The following is a description of a gene set: Mouse Gene Set: MCCLUNG_COCAIN_REWARD_4WK Genes up-regulated in the nucleus accumbens (a major reward center in the brain) after 4 weeks of cocaine treatment. from publication McClung CA, Nestler EJ (PMID 14566342) DeltaFosB (a truncated form of FosB) and CREB (cAMP response element binding protein) are transcription factors induced in the brain's reward pathways after chronic exposure to drugs of abuse. However, their mechanisms of action and the genes they regulate remain unclear. Using microarray analysis in the nucleus accumbens of inducible transgenic mice, we found that CREB and a dominant-negative CREB have opposite effects on gene expression, as do prolonged expression of DeltaFosB and the activator protein-1 (AP-1) antagonist DeltacJun. However, unlike CREB, short-term and prolonged DeltaFosB induction had opposing effects on gene expression. Gene expression induced by short-term DeltaFosB and by CREB was strikingly similar, and both reduced the rewarding effects of cocaine, whereas prolonged DeltaFosB expression increased drug reward. Gene expression after a short cocaine treatment was more dependent on CREB, whereas gene expression after a longer cocaine treatment became increasingly DeltaFosB dependent. These findings help define the molecular functions of CREB and DeltaFosB and identify clusters of genes that contribute to cocaine addiction. studied in species Mus musculus, and this is the list of marker genes: Traf6, Dnajc5, Per1, Gpaa1, Serpinb2, Dclre1a, Dusp6, Klf5 (Kruppel-like transcription factor 5), Znfx1, Kin, Cybc1, Col8a1, Col10a1, Itpr2, Zdhhc6, Slc22a21, Inhbc, Klf10, Dnajb1, Papola, Sirt1, Cblif (NCBI Gene Id 14603), She, Il17a, Nr4a1, Epb41, Sox11, Smr2, Serpina1b, Fos, Ugdh, Camk2a, Il3, Guca2a, Unc119b, Ccdc6, Swap70, Clk1, Capn6, Fndc1, Ncs1, Cryge, Ciao2b, Actr1a, Il1r2, Apoh, Nfatc2, Wnk1, Pdpk1, Klf4, Smarca4, Zap70, Tectb, Tug1, Corin, Tcf3, Blk, Serpinb3a, Fmr1nb (Fmr1 neighbor), Pisd, Slc35d1, Ankhd1, Coro2b, Rangap1, Nusap1 (nucleolar and spindle associated protein 1), Kif1b, Aass (NCBI Gene Id 30956), Dusp1, Pdxk, P4ha1, Klra7, Caml, Pbx1, Nell2 (NCBI Gene Id 98001), Ada